Given this list of marker genes Smad4, Tacstd2, Hoxb7, Greb1l, Smo, Hoxa11, Sox9, Fgf2, Bmp2, Six1, Wnt11, Hes1, Lgr4, Ptch1, Wt1, Wnt1, Wnt9b, Sox8, Dlg1, Wnt4, Fgf8, Osr1, Lhx1, Pspn, Tcf21, Pgf, Eya1, Foxd1, Sall1, Shh, Bmp4 (bone morphogenetic protein 4), Pax8, Ctns, Gpc3, Irx3, Timeless, Agt, Commd5, Lzts2, Col4a1, Vegfa, Pax2, Gata3, Gzf1, Pkd2, Ctnnbip1, Grem1, Fgf1 (fibroblast growth factor 1), Fat4, Wnt2b, Tmem59l, Lama5, BC028528, Lgr5, Bcl2, Mir216b, Agtr1b, Hes5, Hoxd11, Mtss1, Wnk4, Hs2st1, Six2, Fmn1, Kif26b, Npnt, Irx2, Hs3st3b1, Hey1, Pkd1, Klhl3, Dchs1, Maged1, Cited2, Mir216a, Myc, Pbx1, Ctnnb1, Hdac5, Dspp, Agtr1a, Nog, Irx1, Cd44, Gdnf, Hnf1b, Hs3st3a1, Wnt6, Cited1, Mef2c, Ilk, Agtr2, Adamts16, Tgfb1, Gli3, Six4, Mir217, here is a description of the gene set: species: Mus musculus The process in which the renal tubule is generated by specification of cell fate, through the maintenance of cell polarity, regulated cell proliferation and morphogenetic cell rearrangements, shape changes and growth. A renal tubule is a tube that filters, re-absorbs and secretes substances to rid an organism of waste and to play a role in fluid homeostasis. Mouse Gene Set: GOBP_RENAL_TUBULE_MORPHOGENESIS